Given this list of marker genes Pabpc1, Lsm2, Dcp1a, Cnot10, Edc4, Lsm1, Tnks1bp1, Cnot7, Eif4a1, Eif4a2, Lsm6, Lsm4, Cnot4, Edc3, Patl1, Dcp2 (NCBI Gene Id 70640), here is a description of the gene set: species: Mus musculus part of: Metabolism of RNA electronically inferred by orthology from the curated human pathway Reactome Pathway: Deadenylation-dependent mRNA decay This event has been computationally inferred from an event that has been demonstrated in another species.<p>The inference is based on the homology mapping from PANTHER. Briefly, reactions for which all involved PhysicalEntities (in input, output and catalyst) have a mapped orthologue/paralogue (for complexes at least 75% of components must have a mapping) are inferred to the other species.